The following is a description of a gene set: studied in species Homo sapiens Human Gene Set: HP_INCREASED_MEGAKARYOCYTE_COUNT Increased megakaryocyte number, i.e., of platelet precursor cells, present in the bone marrow. Increased megakaryocyte count, and this is the list of marker genes: SH2B3, JAK2, MPL, TP53, SF3B1, TET2, GNE, CALR